The following is a description of a gene set: Pathway Definition from KEGG: (NLRP3+PYCARD) -> CASP1 -> (IL1B,IL18,IL33) NLRP3 inflammasome signaling pathway. Pathway ID: N00742. Pathway type: Reference. Pathway class: nt06521 NLR signaling. Human Gene Set: KEGG_MEDICUS_REFERENCE_NLRP3_INFLAMMASOME_SIGNALING_PATHWAY studied in species Homo sapiens, and this is the list of marker genes: PYCARD, IL33, CASP1, IL18, IL1B, NLRP3